Given this list of marker genes MED26, SCAI, ADGRL3, AP1G1, TCEANC2, MAPK9, HSF5, PML, RAB33A, SLC30A6, DYRK2 (NCBI Gene Id 8445), LPGAT1, MYORG, TGFBR3, PDE3B, HNRNPF, OTOGL, RNF19A (NCBI Gene Id 81036), MEF2C, APOA2, TMEM30A, CD28, WNT2, SKIC3, LMBRD1, TSHZ2, KDELR2, PRKAB2, PRR16, NEDD4, AMOT, E2F6, PRKAG2, ITPR2, RAB3GAP2, DPYD, HDGFL3, C19orf12, GORAB, HIF1A, FBXL20, GNL3L, NRG1, ZNF571, TSPAN12, CNKSR2, ANTXR1, GOLGA4, ZFYVE28, ZNF461, PATZ1, GMFB, SPINT1 (serine peptidase inhibitor, Kunitz type 1), DCUN1D4, BCL11A, TREM1, TENM3, CYP4X1, DNM3, VWA8, ARGLU1, CENPL, COPB1, WASHC5, ACVR2B, CHD6, RRAGA, LRRC4, SSH1, USP42, PRSS54, PPARGC1A, SGCB, CUL5, SLC35G1, DCTN6, USP10 (ubiquitin specific peptidase 10), VAV3 (vav guanine nucleotide exchange factor 3), POU2F1, UBE2Q1, GPCPD1, NDUFA5, RAPH1, FRY, APPL1, DCBLD2, INIP, FNIP1, USH2A, PEAK1, RINT1, MCTP1, SLC9A2, RNF38, KRT34, GPR85, TMEM176B, KIAA0930, ANKRD6, RNMT, TMEM74 (NCBI Gene Id 157753), LSM8 (LSM8 homolog, U6 small nuclear RNA associated), DICER1, EPHA7, TNPO1, F5, SMPDL3A, PABIR2, ENDOU (endonuclease, poly(U) specific), CDKL4, MAP3K9, XPNPEP3, RAB3IP, GPR26, MAP1B, GPRASP2, KIF13A, FDX1, CYP2C8, PPM1B, DPY19L2, LRRN1, ARMCX3, SLC25A31, LDLRAD4, SPATA13, FBP1 (fructose-bisphosphatase 1), OTUD4, PPDPFL, CRYM, MSI2, ZNF407, CYP2C19, NF1, EPHA3, TARDBP, KCTD16, BTN3A2, WNT11, PDCL, DCDC2, AHCTF1, CDC42BPA (NCBI Gene Id 9876), ZBTB20, MIEF1, PRP4K, SLC39A10, ANKIB1, DCDC1, JOSD1, EBLN2, VDAC1, SNRPB2, UHMK1, PF4V1, SLC9A6, MAGI3, ANO3, GLT8D1, RLN1, KATNBL1, MBD1, KITLG, DLEU7, SCN8A, SIKE1, KHDRBS2, TGM2, CLCN3, PHF6, YTHDF1, SETD5, MYT1L, ETS1, FXR1, DYNC1LI2, MATN2, DNAJB4, RWDD4, SUN2, PPM1E, ZBED1, CDK6, HOXD9, CREB1, TMEM132B (NCBI Gene Id 84462), SLITRK4, BTBD7, GKAP1, MCC, SET, PDE4D, KIF5C, MFN2, WDR20 (NCBI Gene Id 91833), SEPSECS (NCBI Gene Id 51091), ZBTB18, TP63, ADCY7, PTPN4, NSMAF, PJA2, TOMM70, NEDD9, ANKS6 (ankyrin repeat and sterile alpha motif domain containing 6), CBFB, ITGB1BP1, ATL2, PRKACB, KIF23, TTC14, ABCB5, MINDY2, EFR3B, KDM5B, FEM1B, TNRC6B, WDFY3, FGFR2, LIX1, ZNF474, BTN3A1, ZC3H12C, CD1E, SYNDIG1, PPP6C, ATXN7L1, SLC4A10, SH3GLB1, CDYL2, ASH1L, ASB4, CXCR6, FBXO45, CNOT9 (CCR4-NOT transcription complex subunit 9), FOXP1, RUBCN, KLF12, CRYBG1, ZNF704, PLS3, KLHL21, EIF1AX, ZNF7, TRIM71 (NCBI Gene Id 131405), DYRK1A, HECA, TMEM14B, UBP1 (upstream binding protein 1), FGF12, YAP1, KIF21A, ABCA5, BTLA, RORA, TMCC1, PELI2, USP24, IL1RAP, KMT2A, SV2C, ELK4, ZBTB21 (zinc finger and BTB domain containing 21), PPP6R2, RHBDL2, GAB1, RAB11FIP2, KLHL9, SRSF11, TLK1, FRS2, RBM24, CAB39, ZNF19, TPM3, ST13, NEK2, JADE1, APOOL (apolipoprotein O like), NR2C2, TBKBP1, KASH5, BCL2L11, DLL1, PARP14, SMURF2, ADK, here is a description of the gene set: from publication Chen Y, Wang X (PMID 31504780) studied in species Homo sapiens Human Gene Set: MIR4310 Genes predicted to be targets of miRBase v22 microRNA hsa-miR-4310 in miRDB v6.0 with MirTarget v4 prediction scores > 80 (high confidence targets).